The following is a description of a gene set: Reactome Pathway: Glycoprotein hormones More complex protein hormones have carbohydrate side chains and are called glycoprotein hormones. Hormones in this class are Follicle-stimulating hormone (FSH; follitropin), Luteinizing hormone (LH), Thyroid-stimulating hormone (TSH; thyrotropin) and human chorionic gonadotropin (hCG). The alpha subunit of glycoprotein hormones is a 92 aa peptide and serves as the alpha subunit for FSH, LH, hCG and TSH (Fiddes JC and Goodman HM, 1981). The beta subunits for these hormones are unique and confer biological specificity to them. These two subunits combine via disulphide bonding to produce the mature glycoprotein hormone dimer. species: Homo sapiens part of: Peptide hormone biosynthesis, and this is the list of marker genes: INHBE, TSHB, INHBB, INHBA, LHB, INHA, INHBC, CGB3, FSHB, CGA